The following is a description of a gene set: Human Gene Set: GOBP_LYSINE_METABOLIC_PROCESS species: Homo sapiens The chemical reactions and pathways involving lysine, 2,6-diaminohexanoic acid., and this is the list of marker genes: PIPOX, CRYM, HYKK, SLC25A21, DLST, AASS, AADAT